The following is a description of a gene set: species: Homo sapiens RNA Polymerase II Transcription Termination Human Gene Set: REACTOME_RNA_POLYMERASE_II_TRANSCRIPTION_TERMINATION, and this is the list of marker genes: SLU7, SRSF9, PAPOLA, PCF11, POLDIP3, CHTOP, SNRPG, CSTF3, MAGOHB, SNRPE, CLP1, ZNF473, NUDT21, SYMPK, CASC3, ALYREF, U2AF2, SRSF7, SRSF1, SRSF3, DDX39B, DHX38, UPF3B, U2AF1L4, LUZP4, SNRPB, LSM11, THOC5, CPSF7, SRSF5, CPSF4, SRSF6, FYTTD1, SARNP, THOC7, CSTF1, SNRPF, CPSF3, MAGOH, CPSF1, SLBP, SRRM1, LSM10, THOC6, CSTF2, RBM8A, NCBP2, CPSF6, SRSF2, U2AF1, DDX39A, THOC1, ZC3H11A, EIF4A3 (NCBI Gene Id 9775), THOC2, CSTF2T, NCBP1, FIP1L1, SRSF11, PABPN1, WDR33, CDC40, CPSF2, THOC3, RNPS1, SNRPD3, SRSF4